Given this list of marker genes R3HDM1, BMAL2, AGBL1, KATNAL2, TNFRSF11B, TCERG1, SNAP25, SREK1IP1, EBF1, KLRK1, MRGPRX2, LRPAP1, TCIM, BPIFB4, SSR2, IRF2, SLC5A12, THRB, CTNND1, PDZD11, LMLN, EZR, KLHL14 (NCBI Gene Id 57565), ARFIP2, VIPR1, GAS2L2, SPOCK1, TDRKH, KIF3C, CLIC5, TMEM19, HTR3C, TPX2, OXGR1, ETV1, EFNA5, MSX2 (msh homeobox 2), BTN1A1, CYTH4, KDM3B, CSNK1D, MAP3K20, FAHD2B, ZNF668, GLYAT, WIPF2 (NCBI Gene Id 162601), NEU1, PRKG1, ARHGAP24, SRPK2, CFAP77, AEN (NCBI Gene Id 64782), CEP350, TFG, LCLAT1, ZNRF3, SLC18A2, ORC3, NCKAP5, BZW2, FAM86B1, SUSD4, LOXL2, ONECUT2, ADRA2A, PLCXD2, PAX8, SRSF8, ABCG5, SDK2, HABP4, NBR1, CKMT1A, PEG10 (NCBI Gene Id 651242), PMP22, here is a description of the gene set: studied in species Homo sapiens from publication Chen Y, Wang X (PMID 31504780) Human Gene Set: MIR4294 Genes predicted to be targets of miRBase v22 microRNA hsa-miR-4294 in miRDB v6.0 with MirTarget v4 prediction scores > 80 (high confidence targets).